The following is a description of a gene set: Mouse Gene Set: MIR_324_3P species: Mus musculus from publication Chen Y, Wang X (PMID 31504780) Genes predicted to be targets of miRBase v22 microRNA mmu_miR_324_3p in miRDB v6.0 with MirTarget v4 prediction scores > 80 (high confidence targets)., and this is the list of marker genes: Mrrf, Slc30a6, Zbed3, Fam53c, Nfat5, Mms19, Kcnc2, Fhip1b, Arhgef7, Nsmaf, St18, Prkacb, Farsa, Slc45a3, Slc35a5, Zmym5, Cyp2j11, Prep, Btnl9, Rfx3, Serinc5, Septin2, Zfp236, Phf12, Rab18, Hoxb9, Ube2w, Tab2, Peg10, Gpx7, Twf1, Actr5, Pom121, Ccdc153, Adamts4, Tcf23, Pik3ca, Dcx, Ndst3, Plekhg4, Samd5, Sfpq, Psd3, Ythdc1, Gda, Rogdi, Izumo3, Sptlc3, Gpr61, Cmtm3, Wdhd1, Brdt, Gabra1, Rap2c, Rnps1, Riok3, Sbno1, Adcyap1r1, Stard6, Zdhhc21, Zfp710, Sfxn3, Ppp3ca, Gucy1a2